The following is a description of a gene set: The process by which a virion attaches to a host cell by binding to a receptor on the host cell surface. Human Gene Set: GOBP_RECEPTOR_MEDIATED_VIRION_ATTACHMENT_TO_HOST_CELL studied in species Homo sapiens, and this is the list of marker genes: TMPRSS2, CLEC4M, DPP4, LRRC15, ACE2, GAS6, ICAM1